The following is a description of a gene set: We found that a number of Tfh cells downmodulated BCL6 protein after their development, and we sought to compare the gene expression between BCL6-hi Tfh cells and BCL6-low Tfh cells. Human Gene Set: GSE24574_BCL6_HIGH_TFH_VS_TCONV_CD4_TCELL_DN species: Homo sapiens from publication Kitano M, Moriyama S, Ando Y, Hikida M, Mori Y, Kurosaki T, Okada T (PMID 21636294) Genes down-regulated in BCL6 high follicular helper T cells versus T conv cells., and this is the list of marker genes: SLC16A3 (solute carrier family 16 member 3), CACNB2, HES1, AKR1C4, B2M, DENND2B, UBAC1, NISCH, LDHC, TLR3, HOXB2, TNFRSF25, RFNG, ZNF165, GADD45B, PLEC, LINC01138, FZD1, PLK2, CCND1, NTS, ZNF652, RGS10, RARB, BCAT2, FZD6, NDUFA6, BAK1, LYPD1, AJAP1, DDIT4, LAMA3, CENPB, C14orf132, PDE4C, CDH2, LEFTY2, PHF24, ZNF81, GCHFR, GNRH1, ARHGEF15, AKR7A3, GIP, VAC14, SLC1A1, SPTA1, MALT1, TNFRSF1A, HSD3B1, RNF8, GPNMB, SCN1B, GRIK3, TGFB1, HADH, ANKLE2, PTGS2, GLI2, SLC31A1, PDGFRL (NCBI Gene Id 5157), GPR68, TYRO3, MYT1L, DIS3, FPGS, HAVCR1, RARG, KALRN, FAM168A, MMP14, BMP3, PLCD1, TCL1B, APOBEC3G, TCEA2 (transcription elongation factor A2), TBC1D22A, GSTO1, CRHR1, ZNF862, NSD2, IL6R, STX11, PIEZO1, GYS1, PNPLA4, MRPL19, HLA-DOA, PIAS4, MINDY2, ZNF318, PACS2, KMT2D, LRRTM2, ISG15, VTN, CXCL3, EPAS1, NTSR1, CDK18, CXCL2, ANXA2P1, PPP1R3D, RGS3, FGF1, SLC5A2, SULT1A1, PPT2, VAMP1, ITPR3, P2RX5, RBP4, BAG2, NR3C1, ENTPD3, ABCB11, IFNGR2, TFF1, ID3, ANK1, TIMELESS, RASSF8, RAP1GDS1, INPP5A, ASIP, NFKBIB (NFKB inhibitor beta), GSTA4, UBTF, SH3BP5, SP4, ZNF200, RPS10, ITPKB, EPHB2, PFKL, COG2, KLK13, SERPINB9, CXCL6, ADO, ADAMTSL3, OPTN, DPF1, OXSR1, NR4A1, SLC30A1, CD6, MARCO (macrophage receptor with collagenous structure), RUNX3, CD5, MAGEB2, BUB1, TNFRSF1B, UNC13A, PAX4, TGOLN2, NINJ1, MAD1L1, R3HDM1, RAD51D, FMO5, SLC30A3, PLS1, ID1, NRTN, EPHB6, LGMN, KCNJ8 (NCBI Gene Id 3764), GNAQ, IL16, TNFRSF10B, TOM1, ETV1, SEMA6C, PSMD12, CCL3, ICAM5, MYO7A, ARHGEF1, DUSP3, PTP4A1, PLIN2, TMPRSS2, LEP, HSD17B2, EHMT2, DMTN, GCSH, DSTYK, TNNT1, DUSP5, CCDC106, SYNPO, CDK5R2, MAEA, TPM2, CD9